Given this list of marker genes FERMT1, CAP2, RAB11FIP2, FGF13, ARHGAP35, KIF26B, SPDL1 (NCBI Gene Id 54908), ALPK2, ITGB1, DIAPH3, CARMIL2, KIF2C, CCDC66, DST (NCBI Gene Id 80105), CKAP5, ACTB, KIF20B, SHH, CRB2, SAPCD2, RPGRIP1L, RIPOR2, CDX2, RHOJ, CCL4, ARHGEF11, FEZ1, PLEKHG3, EPHB1, BRSK2, CDC42 (NCBI Gene Id 998), MAP4, ARF4, DOCK8, PARD6G, AMOT, WWC1, NDE1, WNT5A, SH3BP1, GPSM2, SFRP5, PKHD1, MISP, MYH9, HES1, NCKAP1, RAP1B, ROCK2, GSN, SLC9A1, PRICKLE1 (NCBI Gene Id 144165), CTNNA1, ARF6, PTK2, WNT7B, SLC9A6, SPN, DCTN1, CORO7, TCF15, FSCN3, VANGL2, DLG4, PRKCI, BCCIP, FLOT2, ENKD1, MSN, CYRIB, NDEL1, MAP7, RHOA, CRTAM, SDCCAG8, RAC3, ANK1, UBXN2B, RHOBTB2 (Rho related BTB domain containing 2), GOLPH3, ATN1, PARVB, FOXJ1, TTC8, HDAC3, FAT1, PRKCZ, ACTR2, KRIT1, CYTH1, AMOTL1, MTCL1, SIPA1L3, DLG5, SPRY1, MARK2, IFT80, LHX2 (NCBI Gene Id 9355), CLASP2, NUMA1, HTT, PARVA, PARVG, MYO9A, PKD1, PARD6B, MAD2L1, WNT11, MYO18A, FRMD4A, STK25, INPPL1, MAPRE1 (NCBI Gene Id 22919), FOXF1, RHOQ, SNX27, ANKFN1, GJA1, AMOTL2, STK11, ABL2 (ABL proto-oncogene 2, non-receptor tyrosine kinase), CYTH3, DYNLT1, RAC1, CRB3, AQP1, CDH5, DLG1, RUFY3, PARD3B, LLGL1, NPHP3, CRB1, EZR, SKA2, ABL1, KIF25, PDCD6IP, WEE1, OPHN1, CAMSAP3, FAM89B, RAC2, KIAA1614, HES5, RHOBTB1, ARFGEF1, NHERF1 (NHERF family PDZ scaffold protein 1), WDR1, KANK1, UST (uronyl 2-sulfotransferase), SCRIB, MOS, ACTR3, NDC80, DLG3, MPP7, ROCK1, FRMD4B, PLK1, CD3G, CLASP1, LMNA, SHTN1, ERBIN, CENPA, LRRC7, PALS1, CCDC85C, TRAF3IP2, MAP1B, SPRY2, DLG2, CAP1, CRK, PDLIM1, FGF10, CCL19, RACK1, KAT5, LAMA1, CCL21, BRSK1, JAM3, SYNE4, TCIRG1, PHLDB2, CFL1, CRKL, FBXW11, MCPH1, PAX6, FSCN2, CDC42BPB, RAP2A, CLIC4, IFT20, NSFL1C, PARD6A, CCR7, RAB10, KCNJ8, LLGL2, PATJ, RICTOR, CYP26B1 (NCBI Gene Id 56603), GPSM1, SPINT2, IGF1, SKA3, RHOG, PAK1, ZW10, PARD3, PTK7, GSK3B, FSCN1, SKA1, OOEP, DOCK7, GATA3, RHOV, WNT7A, FBF1, SPAG5, ILK, PAFAH1B1, TEK, GBF1, RHOU, NCKAP1L, CDK5RAP2, WDPCP (WD repeat containing planar cell polarity effector), DOCK2, here is a description of the gene set: Any cellular process that results in the specification, formation or maintenance of anisotropic intracellular organization or cell growth patterns. Human Gene Set: GOBP_ESTABLISHMENT_OR_MAINTENANCE_OF_CELL_POLARITY studied in species Homo sapiens